Given this list of marker genes DHRS3, AAGAB, TRPM1, FUZ, IFI35, RPL13, PCCB, DMD, ZNF587, TMEM143, CYTH1, YTHDF2, ZNF224 (zinc finger protein 224), NUP210, HSPA1B, ZEB1, MCTS1, OSBPL2, PCTP, PYROXD1, CRBN, PLPP3 (NCBI Gene Id 8613), GCGR, LIMK2, ABCA7, GEMIN7, NUMA1, CLSTN3, SDHC, ACP2, MAP3K10, SYT1, MIF4GD, TFAP2B, DNAAF8, AKAP5, NOL7, MAD2L2, BMP6, MIEN1, SRPRB, COL4A5, CISH, SINHCAF, LEP, AK3, IGF1, PILRB, MIS18A, MBD5, GPD1, PTHLH, RMDN3, PPP1R11, FLVCR1, CARD16, SYNGR1, SZRD1, RNF139, KIF13A, FOSL2, ALDH1B1, GALC, TRDN, SLC5A1, PFKFB3, WNT3A, HMGN2, FGF13 (fibroblast growth factor 13), DCAF10, LBP, GAS2, SERPINA3, ZNF559, NBPF3, DDX11, SNX2, CFI (complement factor I), KCND1, SPOCK2, PSEN1, SNED1, FERMT2, ATXN3, UQCC2, ENOX1, DLX5, CHCHD6, DNAJB1 (NCBI Gene Id 3337), FRMD4A, TRIP4, MAP4K2, BET1L, TIMP1, AZGP1, AP1S1, DDX17, HLA-DPA1, NDUFAF3, EPHX2, RAB3GAP2, YPEL3, PTPRS, ATE1, SIL1, THEMIS2, LHX3, CEBPD, CCNB1, PMS2P1 (NCBI Gene Id 5386), BOD1L1, HS6ST1, ACSL3, GTPBP3, HLA-DRB4, CYRIA, here is a description of the gene set: species: Homo sapiens Genes in the cancer module 427. Human Gene Set: MODULE_427